Given this list of marker genes Hadha, Mecr, here is a description of the gene set: part of: mitochondrial fatty acid beta-oxidation of saturated fatty acids This event has been computationally inferred from an event that has been demonstrated in another species.<p>The inference is based on the homology mapping from PANTHER. Briefly, reactions for which all involved PhysicalEntities (in input, output and catalyst) have a mapped orthologue/paralogue (for complexes at least 75% of components must have a mapping) are inferred to the other species. studied in species Mus musculus electronically inferred by orthology from the curated human pathway Reactome Pathway: Beta oxidation of decanoyl-CoA to octanoyl-CoA-CoA